Given this list of marker genes Numb, Tuba1c, Arrb2, Intu, Dzip1, Sel1l, Psmc2, Gli2, Adcy9, Adcy4, Kif7, Psmd1, Gpr161, Tubb2a, Gas8, Wdr19, Prkaca, Tubb1, Erlec1, Smurf1, Os9 (amplified in osteosarcoma), Gsk3b, Psmd3, Derl2, Fuz, Adrm1, Tuba4a, Ulk3, Ihh, Hhat, Tulp3, Prkacb, Adcy3, Ift57, Adcy6, Psmd14, Spop, Itch (NCBI Gene Id 77732), Gli1, Gpc5, Psmb3, Tuba3a, Syvn1, Mks1, Psmd2, Psmd12, Tuba1a, Tubb3, Dhh, Ttc21b, Cul1, Psmc6, Arrb1, Ift140, Smurf2, Cdc73, Uba52, Ubb, Ofd1, Prkar1a (NCBI Gene Id 80472), Prkar1b (protein kinase, cAMP dependent regulatory, type I beta), Evc, Adcy8, Gli3, Adcy5, P4hb, Tubb6, Smo, Evc2, Ptch1, Psma7, Adcy1, Hhip, Vcp, Csnk1a1, Uba52rt, Psmc4, Disp2, Scube2, Notum, Psmb7, Psmd6, Psmb4, Psma4, Psmd7, Cul3, Wdr35, Ift172, Psmc5, Psmd8, Psmb2, Psmb6, Adcy7, Psmc3 (NCBI Gene Id 19182), Gas1, Ift52, Tubb2b, Rps27a, Psmd13, Tubb4b (tubulin, beta 4B class IVB), Kif3a, Psmb5, Tuba3b, Psma2, Tuba1b, Rbx1, Cdon, Adcy2, Psma5, Shh, Psmd11, Rpgrip1l, Psma6, Skp1, Tubb4a, Psmb1, Psma3, Ift122, Adcy10, Dync2h1, Psma1, Sufu, Grk2, Ubc, Spopl, Psmc1, here is a description of the gene set: studied in species Mus musculus Mouse Gene Set: REACTOME_SIGNALING_BY_HEDGEHOG Signaling by Hedgehog